Given this list of marker genes PLCD1, ITPR1, PLCD4, PLCD3, ITPR3, ITPR2, here is a description of the gene set: Human Gene Set: KEGG_MEDICUS_REFERENCE_CA2_PLCD_ITPR_SIGNALING_PATHWAY Ca2+-PLCD-ITPR signaling pathway. Pathway ID: N01655. Pathway type: Reference. Pathway class: nt06528 Calcium signaling. Pathway Definition from KEGG: Ca2+(cyto) -> PLCD -> IP3 -> ITPR -> Ca2+(cyto) studied in species Homo sapiens